The following is a description of a gene set: Human Gene Set: GOBP_LEARNING studied in species Homo sapiens Any process in an organism in which a relatively long-lasting adaptive behavioral change occurs as the result of experience., and this is the list of marker genes: EPM2A, OPRK1, ATXN1, PDE1B, FOXP2, MECP2, PGRMC1, KRAS, B4GALT2, RAG1, SLC24A2, GPR88, HIF1A, NEUROD2, PDE8B, GMFB, DRD1, ABCA7, ARF4, SLC6A1, NLGN4X, DRD5, SLC12A5, PAK6, MAP1A, NPAS4, ITGB1, TANC1, PIAS1, NPTX2, SORCS3 (sortilin related VPS10 domain containing receptor 3), VDAC3, DDHD2, SYNJ1, TNR, ABCC8, SYT11, SRF, CIC, SLC6A4, NETO1, CSMD1, TACO1, SHANK2, ASIC1, TBR1, AAAS, DEAF1, BRAF, GRM5, VDAC1, RAPGEF3, KMT2A, COMT, HRH1, SLC7A11, HTR2A, PPP1R1B, GRIA1, PAK5, KIAA0319, TH, EN1, TLR2, SPECC1, CLN3, PIANP, PLN, PPP1R9B, GRIN2A, DLG4, JPH4, LRRN4, APP, GRIN1, JPH3, FGF13, DRD3, TUBA1A, YTHDF1, DBH, SHANK1, RGS14, SLC8A3 (solute carrier family 8 member A3), CREB1, SLC8A2, PPT1, CHST10, PPP3CB, BRSK1, ATXN1L, STRA6, ATAD1, UCN (urocortin), CLSTN2, CRH, BCHE (NCBI Gene Id 590), NTRK2, CTNS, NF1, GIT1, ADCY3, EIF2AK4, TTC36, NDRG4, TPBG, NLGN4Y, IFT20, GABRA5, PRKN, GABRB3, NRXN1, HMGCR, KIT (NCBI Gene Id 5086), SLC1A1, NRXN2, CNTN2 (NCBI Gene Id 6900), NRGN, FOS, EPHB2, PRKAR2B, DKK1, NLGN3, PLCB1, FOXB1, FYN, MAPK8IP2, INSR, TAFA2, NPS, ATP8A1, NTSR1, SHANK3, TAC1, CHRNB2, SYNGAP1, HTT, DRD2, ATP1A2, ADGRB3, SNAP25, C1QL1, B3GAT1, MEIS2, RELN, BTG2, LGMN, EIF4A3 (eukaryotic translation initiation factor 4A3), ABL1, ELAVL4, RIC8A, TSC1 (NCBI Gene Id 7248), PTN, NRXN3, CDK5, TACR2, CNTNAP2, ADAM2, CLN8, NOG, TACR1, CLDN5